The following is a description of a gene set: Role of LAT2/NTAL/LAB on calcium mobilization Human Gene Set: REACTOME_ROLE_OF_LAT2_NTAL_LAB_ON_CALCIUM_MOBILIZATION species: Homo sapiens, and this is the list of marker genes: IGKV1-5, IGKV1-17 (immunoglobulin kappa variable 1-17), IGKV4-1, IGLV3-25, IGLV3-19, PIK3R2, IGHV4-59, IGKV3-11, SOS1, PIK3CA, IGLV2-14, IGHV3-11, IGLV1-40, FCER1A, IGKV2-28, IGHV1-69, IGKV1D-16, IGLV2-11, IGKV1D-33, MS4A2 (membrane spanning 4-domains A2), IGLV1-47, IGHV4-34, IGHV2-5, PDPK1, IGKV2D-40, PIK3R1, IGKV3D-20, IGKV5-2, SYK, FYN, IGKV1-12, IGKV2D-30, IGHV3-48, IGKV1D-39, IGHV2-70, IGHV4-39, IGKV1-33, IGLV2-8, IGKV2-30, IGKV1D-12, SHC1, IGKV1-16 (immunoglobulin kappa variable 1-16), IGLV3-27 (immunoglobulin lambda variable 3-27, NCBI Gene Id 28791), IGLV3-21, GAB2, IGHV1-46, IGHE (NCBI Gene Id 388026), IGHV3-53, FCER1G, IGLV1-44, IGHV1-2, IGLV3-1, IGHV3-7, LYN, IGLV7-43, IGKV2D-28, IGKV1-39, IGKV3-15, IGHV3-23, IGHV3-33, IGLC2, LAT2, IGLV2-23, IGLV6-57, IGLC3, IGHV3-30, IGKV3-20 (immunoglobulin kappa variable 3-20), PIK3CB, IGHV3-13, GRB2, IGLV1-51